Given this list of marker genes Bsn, Thoc1, P2rx1, Hdlbp, Dusp1, Gtf2i, Ptafr, Cpeb2, Liph, Thoc2, Rgs6, Thrsp, Rab8b, Tmod2, Slc66a1, Bcat1, Pcdh19, Hif3a (hypoxia inducible factor 3, alpha subunit), Fasl, Ddx19b, Egln2, Slc14a2 (solute carrier family 14 (urea transporter), member 2), Dbndd2, Ago4, Plpp6, Fign, Ppp1r16b, Ercc4, Zfp644, Mdm4, Arpp19, Adamts15, Dtx2, Slc30a4, Trim67, Igf1, Uhrf2, Igf1r, Ehhadh, Slc16a14, Lmx1a, Kif2b, Ttll4, Dcaf15, Rufy3, Prtg, Stk40, Lbr, Plekhg6, Hif1an, Ap1s1, Igdcc4 (NCBI Gene Id 56741), Fndc3b, Abcc5, Gpr137b, Bend4, Smim13, Pbx3, Vstm5, Gpatch2, Osbpl3, Nek3, Hand1, Elf4, Cgnl1, Cbx2, Lpgat1, Pappa, Zc3hav1l (zinc finger CCCH-type, antiviral 1-like), Tmc7 (NCBI Gene Id 69500), Rbms2, Nme6, Mier1, Mroh6, Rdx, Slc20a1, Galnt2, Pxdn, Elp1, Piga, Ikzf2, Tyk2, Grid2ip, Trabd, Dnaja2, Smug1, Eea1, Il13, Zfp617, Dlc1, Onecut3, Cpeb3, Gpr157, Dagla, E2f6, Pacs2, Hook1, Fam135a, Slc35d2, Zfp975, Sigmar1, Entrep2, Diaph2, Slc38a9, Onecut2, Clpb, Fnip1, Tmprss11f, Kctd17, Hoxa1, Snn, Gab2 (NCBI Gene Id 14389), Syt11, Ccnj, Klhl31, Gpatch3, Cflar, Rnf5, Rasgrp1, Cacnb4, Map3k2, Pde12, Rbpj, E2f2, Dnajc1, Trim6, Tmed5, Ing3, Slc7a14, Epha3, Arih1, Pld3, Tet3, Soat2, Vsnl1, Pcgf3, Kif21b, Faxc (failed axon connections homolog), Dtx4, Mycn, Cercam, Slc5a9, Clasp2, Prkaa2, Coil, Kctd21, Tmem198b, Prpf38b, Plxnc1, Ercc6, Fndc3a, Lrig3, Myorg, Ints2, Lrig2, Arl5a, Tcte1, Pard6b, Pald1, Wdfy3, Mycbp, Naa30, Zfp275, Cldn12, Ybey, Zswim5, Senp5, Impg2, Sdk1, Homer2, Arid3c, Stx17, Cpa4, Map4k4, Map3k1, Gga3, Senp2, Fgd6 (NCBI Gene Id 13998), Acat1, Atp2b4, Wnt9a (wingless-type MMTV integration site family, member 9A), Slc22a23, Gramd2b, Snx16, Trim71, Utrn, Map3k3, Cnot6l, Tmem65, Esr2, Slc2a12, Arid3b, Numbl, Pik3ip1, Vipr1, Rab40c, Cep135, E2f5, Dnaaf9, Dmd, Scn11a, Zmat4, Adamts12, Ppargc1b, Igf2bp3, Usp24, Fras1, Gale, Klhl6, Psd3, Abcg1, Adrb2, Smarcad1, Ahctf1, Gcat, Tmem121b, Tgfbr1, Xkr8, Slc10a7 (solute carrier family 10 (sodium/bile acid cotransporter family), member 7), Begain, Sestd1, Ints6l, Txlng, Ppp1r15b, Rcn1, Plekha8, Bach1, Greb1l, Dennd6a, Yod1, Eef2k, Peg10, Lin28a, Cry2, Fnip2, Snx30, Macf1, Igf2bp1, Pogz, Tgds, Masp1, Cbx5, Cd200r1, Nr6a1, Rbfox2, Klf8, Mapk8, Dffa, Ddx19a, Ndst2, Slc25a24, Adrb3, Leprotl1, Hmga2, Ccr7, Alox8, Mllt10 (NCBI Gene Id 338532), Katnbl1, Trhde, Hmga1, Sall4, Intu, Nkapd1, Nynrin, Abcb9, Il10, Nras, Rgs16, Nphp3, Smarcc1, Zfp710, Hk2, Gas7, Hip1, Plcxd2, Ltn1, Tmprss2, Col1a2, Gxylt1, Brwd1, Dna2, Arhgap12 (NCBI Gene Id 75415), Rictor, Limk2, G6pc2, P4ha2, Mdfi, 1700017B05Rik, Wasl, Sema4c, Vav3, Dpp3, Brd3, Fgf11, Nap1l1, Stxbp5, Ergic2, Stx3, Fam174a, Col5a2 (NCBI Gene Id 73740), Spryd4, Klk10, Pkn2, Rspo2, Gdpd1, Etnk2, Lgr4, Tcf7l1, Nol4l, Dusp22, Gatm, Gcnt4, Slc6a1, Tspan5, Zfp583, Septin12 (NCBI Gene Id 75648), Lipt2, Zfyve26, Sowaha, Rdh10, Atl2, Fignl2, Ccdc71l, Myo1f, Epha4, Apbb3, 9930012K11Rik, Plxna4, Arhgap28, Gdf6, Tepsin, Strbp, Sall3, Lalba, B3gnt7, Stard13, Cemip2, Sec16b, Pcdh20, Fgf4, Prr23a3, Uggt1, Zfp282, Taf9b, Hic2, Igdcc3, Tgfbr3, Fam184b, Hoxa9, D630045J12Rik, Usp47, Acp3, Zfp512b, Igf2bp2, Col27a1, Smim3, Hectd2, Slc25a27, Gabra6, Stox2, Crb2, Plekho1, Surf4, Usp38, Nlrc5 (NLR family, CARD domain containing 5), Tnfaip8l3, Col3a1, B4gat1, Efhd2, Cdc34, Lin28b, Hoxb1, Adamts8, Alg11, Col4a1, Akap6, Slf2, Fbxl12, Eif4g2, Tmco1, Fam83g (NCBI Gene Id 69640), Cpeb1, Arid3a (AT-rich interaction domain 3A), Casp3, Kdm3a, Edn1, Ammecr1l, Rab11fip4 (RAB11 family interacting protein 4 (class II)), Pbx2, Ngf, Mfsd4a, Frmd4b, Has2, Dnase1l2, Col4a2, Osmr, Bzw1 (basic leucine zipper and W2 domains 1), Amot, Mxd1, Clp1, Plpp5, Zbtb5, Ccnd2, Trim41, 5031439G07Rik, Ccdc89, Cep120, Plxnd1, Slc12a9, 2310022A10Rik, Skil, Atp2a2, Asap1, Pla2g3, Ppp2r2a, Styk1, Pbx1, Sft2d3, Gnptab, Rfx6, Zbtb39, Gpcpd1, Zfp568, Ddi2, Il6, Nme4, Cntrl, Scyl3, Ugcg, Agap1, Ago3, Tmem167, Tbkbp1, Crtam, Gng5, Arhgef15, Atp8b4, Mapk6, Gpr156, Wnt9b, Ttl, Map4k3, Nemp1, Zfp473, Prrx1, Galnt1, Acvr2a, Nipal4, Stimate, Limd2, Pitpnm3, Acvr1c, here is a description of the gene set: species: Mus musculus Genes predicted to be targets of miRBase v22 microRNA mmu_miR_1961 in miRDB v6.0 with MirTarget v4 prediction scores > 80 (high confidence targets). Mouse Gene Set: MIR_1961 from publication Chen Y, Wang X (PMID 31504780)